The following is a description of a gene set: Apoptosis studied in species Homo sapiens Human Gene Set: REACTOME_APOPTOSIS, and this is the list of marker genes: NMT1, TNFRSF10A, YWHAE, TP53, TNFSF10, UBC, TP73, KPNB1 (NCBI Gene Id 3837), PSMB3 (proteasome 20S subunit beta 3), HMGB2, SFN, PSMB4, PSMD11, DBNL (drebrin like), PSMB2, PSMD8, BCL2, ARHGAP10, AKT2, PSMD2, TRAF2, TJP1, BAD, LMNB1, ACIN1, YWHAZ, H1-0, TICAM1, DSG1, UACA, CASP6, DSP (desmoplakin), PSMB6, FAS, BAX, PPP3R1, PSMA7, TRADD, APAF1, STAT3, DYNLL2, PSMC2, CFLAR, UBA52, BAK1, RIPK1, OMA1, KPNA1, PKP1, TICAM2 (TIR domain containing adaptor molecule 2), PSMD3, GSDMD, PSMD13, HMGB1, H1-4, RPS27A, BIRC2, AVEN, TFDP1, H1-1, GSN, PSMA6, PPP3CC, ADD1, YWHAH, MAPK3, DIABLO, DAPK2, PTK2, PPP1R13B, E2F1, CASP8, CDKN2A, PRKCQ, PSMD6, PSMA3, TLR4, AKT3, MAPK1, PRKCD, BMF, DYNLL1, STK24, AKT1, VIM, CD14, PSMA1, DCC, STK26, FNTA (NCBI Gene Id 2339), PSMB5, C1QBP, BCL2L1, TP63, PSMA4, PMAIP1, TNFRSF10B, APC, BCAP31, APIP, PAK2, H1-5, DFFB, YWHAB (NCBI Gene Id 7529), FADD, CASP9, CTNNB1, MAPK8, CDH1, GZMB, MAPT, BCL2L11, MAGED1, OPA1, BBC3, ROCK1, FASLG, ADRM1, PSMD12, PSMD14, OCLN, DNM1L, SATB1, DSG2, CASP7 (NCBI Gene Id 840), DAPK1, APPL1, UNC5B, DAPK3, YWHAG, PSMC6, PSMA5, LY96, PLEC, UBB, PSMD7, CYCS, PSMB1, PSMC4, XIAP, TFDP2, PSMA2, GAS2, BID (BH3 interacting domain death agonist), TP53BP2, TJP2, PSMB7, CARD8, SEM1, GSDME (gasdermin E), CLSPN, YWHAQ, UNC5A, DSG3, PSMC1, H1-2, PSMC3, SEPTIN4, H1-3, CASP3, DFFA (DNA fragmentation factor subunit alpha), PSMC5, BMX, SPTAN1, LMNA, PSMD1